Given this list of marker genes TTR, RLBP1, RDH16, SDR9C7, RBP4, RHO, RBP3, DHRS9, LRAT, RDH10, HSD17B1, RDH5, RDH12 (retinol dehydrogenase 12), MYO7A, RDH11, RPE65, ABCA4, HSD17B6, RBP1, STRA6, RDH8, CYP4V2, here is a description of the gene set: studied in species Homo sapiens Human Gene Set: REACTOME_THE_CANONICAL_RETINOID_CYCLE_IN_RODS_TWILIGHT_VISION The canonical retinoid cycle in rods (twilight vision)